Given this list of marker genes St8sia3, Tmem200c, G6pc3, Chrm1, Sgms1, Rasgrp4, Slc41a1, Fam167b, Cox15, Rab4b, Fosl1, Aptx (NCBI Gene Id 66408), Tmem141, Eeig1, Ppp1r11 (NCBI Gene Id 76497), Cacul1, Fcgr4, Gtf3c2, Nectin1, Smim10l1, Acy3, Wasl, Prickle2, Slc25a23, Alg11, Scara5, Bcl2, Unc13c, Ntsr1, Rcan2, Ap1s1, Nrk, Tmem143, Sf3b1, Taf12, Zfp558, Prkcb, Ube3a, Snx4, Pld2, Abhd6, Praf2, Gon4l, Ap1s2, Erlin1, Calcoco1, Ppp1r10, Cnga2, Foxp3, Ilk, Adam15, Clec9a, Cbx6, Igf2bp3, Zfp114, Prss3b, Ppp3cb, Slamf6, Fcgrt, Aox4, Slc7a1, Ndor1, Dennd2a, Cyp2b23, Mal, here is a description of the gene set: studied in species Mus musculus Mouse Gene Set: MIR_5120 from publication Chen Y, Wang X (PMID 31504780) Genes predicted to be targets of miRBase v22 microRNA mmu_miR_5120 in miRDB v6.0 with MirTarget v4 prediction scores > 80 (high confidence targets).